The following is a description of a gene set: TREM-1 is an orphan immunoreceptor expressed on monocytes, macrophages, and neutrophils. TREM-1 associates with and signals via the adapter protein DAP12/TYROBP, which contains an immunoreceptor tyrosine-based activation motif (ITAM). TREM-1 activation by receptor cross-linking is pro-inflammatory, and can amplify cellular responses to Toll-like receptor (TLR) ligands such as bacterial lipopolysaccharide (LPS). To investigate the cellular consequences of TREM-1 activation, we have characterized global gene expression changes in human monocytes in response to TREM-1 cross-linking in comparison to and combined with LPS. Both TREM-1 activation and LPS up-regulate chemokines, cytokines, matrix metalloproteases, and PTGS/COX2, consistent with a core inflammatory response. However, other immunomodulatory factors are selectively induced, including SPP1 and CSF1 (i.e., M-CSF) by TREM-1 activation and IL-23 and CSF3 (i.e., G-CSF) by LPS. Additionally, cross-talk between TREM-1 activation and LPS occurs on multiple levels. While synergy in GM-CSF protein production is reflected in commensurate mRNA abundance, comparable synergy in IL-1b protein production is not. TREM-1 activation also attenuates the induction of some LPS target genes, including those that encode IL-12 cytokine family subunits. Whereas positive TREM-1 outputs are abolished by the PI3K inhibitor wortmannin, this attenuation is largely PI3K-independent. These experiments provide a detailed analysis of the cellular consequences of TREM-1 activation, and highlight some of the complexity in signal integration between ITAM- and TLR-mediated signaling. Human Gene Set: GSE9988_ANTI_TREM1_VS_CTRL_TREATED_MONOCYTES_UP from publication Dower K, Ellis DK, Saraf K, Jelinsky SA, Lin LL (PMID 18292579) Genes up-regulated in comparison of monocytes treated with anti-TREM1 versus monocytes treated with control IgG. studied in species Homo sapiens, and this is the list of marker genes: NSMAF, GNA13, SLC3A2, NR4A1, ATP2B1-AS1, DYRK3, BAG3, RRN3P2, MMP10, ADM (adrenomedullin), HBEGF, BANP, SGMS1, B3GNT5, SLC2A3, CSRNP1, SPAG5, KBTBD8, MOAP1, RGCC, SNX33, KLHL6, RAB20, ABL2, CSF1, SELENOK, PLAUR, EFR3A, RIT1, ANKRD28, CXCL2, LPL, FNIP2, SGMS2, USP12 (ubiquitin specific peptidase 12), ZFYVE16, CEBPB, STARD8, PTGS2, FOSL1, PHACTR1, PLEKHM1, RABGEF1, EDN1, NRROS, SNUPN, MELTF, INHBA, MMP19, STX4, PLPP3, NR3C1, EGR2, CTSLP8, SPAG9, LY9 (lymphocyte antigen 9), JUN, STX3, DUSP4, RRAGC, DUSP5, SRXN1, TXN, USP53, CHSY1, DTL, EGR1, FAM131A, RHEB, CHAC1, DUSP1, PRKAG2, NR4A2, RASGEF1B, MAFG, ZBTB21, HOMER1, CTSV, NRIP3, XIAP, TBC1D2, LONRF3, RRAGD, ELL2, HES4, RAB1A, TBC1D7, GTF2A1, ETS2, TNFSF15, GCLM, NAA50, GPRC5A, LRRC8B, CDKN1A, SESN2 (NCBI Gene Id 83667), LINC-PINT, DCSTAMP, FERMT2, GLA, MIR22HG, ADO, DUSP2, DUSP3, PTPRE, SGK1 (serum/glucocorticoid regulated kinase 1), S1PR3, PLCXD1, HSPA9 (NCBI Gene Id 91471), ZBTB43, ETF1, HECW2, GADD45B, TMEM38B, SPINK1, NMRAL2P, TBC1D22B, PMAIP1, SMIM13, TMEM70, MAFK, SPART, EGLN3, SLC38A2, COQ10B, ZC3HC1, GFOD1, GEM, MAPK6, GCNA, SLCO4A1, TNFSF14, JMJD1C, F3, GNPDA1, PHGDH, COL15A1, CRADD (NCBI Gene Id 8738), CXCL8, GPCPD1, TLNRD1, THBD, OSGIN1, RREB1, TXNRD1, HIC1, EGR3, ST3GAL6, RNF19A, CRTAM, TNF, TGIF1, TMEM217, ELOC, SPP1, RGS1 (NCBI Gene Id 5996), ESYT2, KLF10, RASD1, PPFIA1, PPARG, RRAD, LINC01010, SPRY2, TFRC (NCBI Gene Id 7037), LBX2-AS1, IL1R1, ATF3, TRIB1, RYBP, DDX5, KLHL21, LYSET, DYNLT2B, DDIT4, SNX9, TCEAL9, CKS2, CLDND1, CTSL, CNST, SNAPC1, PHLDA1, AFF4, LRFN4, ATP6V1B2, NPC1, ACSL3, HAVCR2, NEU1 (NCBI Gene Id 4758), ZNF674-AS1, TAF9, UPP1, PTP4A1, ASPH, MT1E, SH3BP5, PNP